Given this list of marker genes SMARCA1, HMGXB4, C17orf49 (NCBI Gene Id 124944), RBBP4, SMARCA5, BPTF, RBBP7, here is a description of the gene set: An ISWI complex that contains an ATPase subunit of the ISWI family (SNF2L in mammals), a NURF301 homolog (BPTF in humans), and additional subunits, though the composition of these additional subunits varies slightly with species. NURF is involved in regulation of transcription from TRNA polymerase II promoters. species: Homo sapiens Human Gene Set: GOCC_NURF_COMPLEX